The following is a description of a gene set: studied in species Homo sapiens Human Gene Set: GOBP_DORSAL_VENTRAL_PATTERN_FORMATION The regionalization process in which the areas along the dorsal/ventral axis are established that will lead to differences in cell differentiation. The dorsal/ventral axis is defined by a line that runs orthogonal to both the anterior/posterior and left/right axes. The dorsal end is defined by the upper or back side of an organism. The ventral end is defined by the lower or front side of an organism., and this is the list of marker genes: DISP1, HOXA2, DMRT3, GREM1, PAX6, TLL1, CXXC4, BMP4, EDN1, CER1, SP8, NOTO, SUFU, SMO, LMX1B, FKBP8, HHIP, FBXL15, FOXN4, VAX2, GLI2, LHX1, FOXG1, TBC1D32, NKX2-2, GREM2, SHH, WNT8B, ACVR1, DSCAML1, DBX1, RNF220, MICOS10-NBL1, OVOL2, WDR19, MDFI, HOXD11, AXIN2, DDIT3, NBL1, FGF8, CHRD, WNT3A, WNT7A, BMPR1B, GPR161, IFT172, TLL2, HOXA11, SMAD6, PSEN1, IFT122, ACVRL1, LRP4, HOXB2, TULP3, IFT52, WNT3, AIDA, NKX2-1 (NK2 homeobox 1, NCBI Gene Id 7080), CTNNB1, LHX3, GSC, DLL4, GLI3, PAX7, NOG, SMAD2, INTU, TTC21B, BMPR1A, CAPRIN2, LHX2, GSX2, PROP1, FOXA1, SIX3, BMP1, SOX1, SOSTDC1, ARL13B, SFRP1, DYNC2H1, EN1, ASCL1, TCTN1, AXIN1, TBX20, WNT8A, PTCH1, TGIF1, GLI1 (NCBI Gene Id 2735)